Given this list of marker genes C4A, S100B, RAB5A, IGF2BP1, SPTBN2, ADCY8, CACNG7, KCNB2, ASIC2, NEGR1, CRYAB, NSMF, SEZ6, PRKAA2, DCTN1, GNA12, ACTA2 (actin alpha 2, smooth muscle), CNTNAP2, LRIT3, CNTF, PTPRF (protein tyrosine phosphatase receptor type F), RPS6, MBP, RPTOR, TOP1, CTNND2, ITGA8, CPLX2, CCT5, KCNK2, RGS8, TRPM5 (NCBI Gene Id 29850), AGRP, PLXND1 (plexin D1), ASS1, CCT3, ATOH7 (atonal bHLH transcription factor 7), KCND3, KCNA2, ADORA1, HCN1, SIAH2, DPYSL3, PDE9A, TRPV2, ADORA2A, SLC22A3, ASCL1 (NCBI Gene Id 429), EPM2A, ANG, PPP1R9B, PRKAA1, RCVRN, RTN4R (NCBI Gene Id 96184), TMPRSS5, NDEL1, HIP1R, PPP2R1A, KCNC2, AGFG1, SOD1, PTPRS, TGFB1, PTK2B, FEZ1, SLC6A1 (solute carrier family 6 member 1), CX3CR1, HDAC6, RAB38, GRIPAP1, KCNQ1, ERCC8, GABBR1, TXNRD2, CYBB, SYNPO, SMURF1, ENO2, FKBP4, TUBB, DBNL, CD200 (NCBI Gene Id 4345), SLC8A1, SPTBN4, FZD5, DNER, TANC1, GRIP1, XRN1, KLHL1, CCR2, SLC6A3, FRMD7, PNOC, MAPK8IP1, DAB2IP (DAB2 interacting protein, NCBI Gene Id 84635), PMM1, CACNA1F, RAB17, SYN1, UNC5C, NGFR (nerve growth factor receptor), EFHC1, GHRH, RGS7BP, NDN, GIGYF2, NMNAT3, GRIA4, P2RX4, SLC12A2, FBXW11, SOS1, KNDC1, GRIK3, MAPK8IP3, NEUROG1, DNAJB1, KCNN1, CCT2, UNC5A (NCBI Gene Id 90249), SHTN1, SLC1A3, LRP8, SRD5A1, CYBA, GABRA5, FLNA, CIB1, SLC2A3, SEZ6L, RTN1, CRMP1, ZPR1, MYO1D, OPRM1, STEEP1, SRSF10, CCT7, GDI1, HTR2A, CXADR, PDE1B, L1CAM, MAPT, MYH10, KCNC3, STRN, ATP13A2, HPCA, ITGA1, LRP6, RACK1, BMPR1B, CRH, CACNA1A, SEZ6L2, SMN2, LYPD6, RNF157, TMC7, TGFB2, PDE1A, MUL1, CSNK1E, CASR, PI4K2A, NCF1, UPF3B, FCHSD1, USH2A, GRIK2, P2RX2, RDH5, GSK3A, RIN3, DISC1, PTPN13, GRIN3B, NRSN1, CACNA1B, CHRNA10, PSD2, NPPA, LPAR1, NRSN2, KLHL14, TRPM2, EFNA2, ERMN, SRD5A2, PJVK, HCFC1, ATP7A, CNKSR2, LRP4, OMP, AMIGO1, YKT6, UCN, GFAP, BRAF, ADCYAP1, SYT11, TACR1, BRINP3, CPNE5, ZNF385A, GNB3 (NCBI Gene Id 2784), VPS35, PHAX, KATNB1, MYO10, KCNB1, LRRK2, CRHBP, NAPEPLD, NF2, G3BP1, GLUL, GRIA2, RPE65, KCNJ2, GAP43, KCNC1, COBL (cordon-bleu WH2 repeat protein), GNAO1, EPHA4, PPP5C, TNF, DSCAM, PRKN, SLC6A2, APOB, PICALM, SLC1A1, SLC8A2, RPL28, AMFR, GABRA2, SMN1, DRP2, CNNM1, BGLAP, HDAC1, BACE1, KIF5A, CFL1, CYGB, VTI1A, BRD1, UBXN2A, KCNN4, MIR107, CPNE6, CNTN2, SLC38A2, SYAP1, STK39, POLR2M, PUM2 (pumilio RNA binding family member 2), TAC1, RAB8A, ROGDI, KCNN2, FMR1, PLXDC1, HSP90AA1 (NCBI Gene Id 89272), TRAK2, NTSR1, SLC12A5, ELOVL5, ATP1B2, SST, CASP8, PAFAH1B1, SLC2A13, TMPRSS3, VTI1B, SEMA4F, MME, SNCB, SERPINI1, CD3E, ITGA4, MAST1, MYOT (NCBI Gene Id 9499), SERPINF1, SIRT2, EPO, RUFY3, OLFM1, OPRK1, ASTN1, RTN4RL1, HCN2, BPTF, HSPA1L, EPHA7, CDK5R1, SEPTIN4, GNAI2, USP33, WDFY3, PACRG, PIEZO2, ADRA2A, APOE, CALCA, SKOR1, SEPTIN14, P2RY1, CLCN2, TMEM266, PGRMC1, MAP2, ELAVL4, RAC3 (Rac family small GTPase 3), APP, TNN, CCT4, PDE1C, ENC1, PYCARD, NDUFS7, ZC4H2, ATP1A3, ASTN2, PTPRN, CPLX1, CNR2, RBM8A, PDYN, SCN1A, TTLL7, STRN3, GRM5, MCRS1, PPT1, KCNK1, HPN (NCBI Gene Id 3249), GNAT1 (NCBI Gene Id 2779), ACTG2, BAIAP2, FADD, PINK1, GLRX5, ADAM11, MPL, MAP1B, WASHC5, ACTA1, TRPC5, CHRNA4, ACTC1, MT-ND1, CD22, SHANK2, PMM2, TUBB4A, SRR, PLK3, CD40, SLC5A7, PITPNM1 (NCBI Gene Id 9600), WHRN, KCNE3, GRIN3A, STMN2, HSP90AB1, ADAM21, C9orf72, INPP5F, RRM1, PRKAR2B, TIAM2 (NCBI Gene Id 340133), PTK7, CASP3, ATP1A2, RTN4RL2, GNAZ, TH (tyrosine hydroxylase), AZIN2, STAU2, IL6ST, VPS13A, DMWD, CACNA1E, AURKA (aurora kinase A), FZD3, TUBB3 (tubulin beta 3 class III), ADNP, FCGR2B, NAP1L4, STAU1, CACYBP, PENK, SLC17A8, ADCY10, SORBS2, SLC3A2, BMPR1A, KCNA1, NPY, P2RY12, PITPNM3, RNF112, SNCAIP, SYNDIG1, NUMA1, NCDN, SLC1A4, VPS16, CHRNA3, ELK1, NRXN1, SLC4A10, KCNN3, SCN1B, RIC3, KCND1, TTBK1, CADM2, RAPGEF2, BRINP1, WDR47 (NCBI Gene Id 22911), CACNA1C, KREMEN1, GRIA1, DVL1, CDK5, CREB3, ITSN1, PTBP2, DTNBP1, PURA, SNCA, PRKCZ, FLNB, GLRA1, CACNG4, NEURL1, S100A5, KLHL24, SCN11A, SLC25A27, SNCG, ITPR3, GABRD, BMPR2, ARC, IAPP, TRPM4, GHR, MAP2K1 (mitogen-activated protein kinase kinase 1), TACR3, CRIPT, KCNJ10 (NCBI Gene Id 3766), CAPN2, GPM6A, DLG2, WNK4, SLC8A3, TCP1 (t-complex 1), ATXN10, SLC1A2, TMEM50A, HTR5A, MAP1A, LMTK2, GLRA3, NTRK1, ARHGEF7, KNCN, APOD, MAPK8IP2, THY1, SLC38A7, CNGA3, P2RX7, KCNC4, BRINP2, TMEM132E, SORL1, EPHB2, SORCS2, RIT2, RLBP1, SLC6A6, FYN, FLRT1, MAGOHB, PSEN1, RAP1GAP (RAP1 GTPase activating protein), DRD2, SYT4, CX3CL1, PPP1R1B (NCBI Gene Id 84152), NAXE, EPHA5, TPX2, GNRH1, NRGN, KCND2, SLC38A1, DPYSL5, OPN4, SLC4A8, AKAP12, SYT5, LUZP1, KCNH1, MAP1S, DDN, PRPH, EIF4A3, CDC42, CYP17A1, ALCAM, FUBP3, DHX36, TBX21, INSR, GAL, NPFF, PALS1, EVX1, CALB1, TMEM100, ZPBP2, ENDOG, CAD, ABL1, AKAP9, RTN4, PPP1CA, UBB, FBXO31, ZNF804A, SLC24A1, HMCN2, GFRA1, UCHL1, INHA, KIF5C, PARK7, CCT8, P2RX6, GNG3 (NCBI Gene Id 2785), DIP2B, here is a description of the gene set: The portion of a cell bearing surface projections such as axons, dendrites, cilia, or flagella that includes the nucleus, but excludes all cell projections. studied in species Homo sapiens Human Gene Set: GOCC_CELL_BODY